The following is a description of a gene set: Human Gene Set: GOBP_MYELOID_LEUKOCYTE_CYTOKINE_PRODUCTION species: Homo sapiens Any process that contributes to cytokine production by a myeloid cell., and this is the list of marker genes: RABGEF1, MYD88, RTN4, TGFB2, TLR4, PANX1, P2RX7 (purinergic receptor P2X 7), SPON2 (NCBI Gene Id 10417), NLRX1, TWIST1, NOD1, DDX21, TLR7 (NCBI Gene Id 51284), TGFB3, CD74, TICAM1, EPX, CARD9, LITAF, AXL, BCL6, LAPTM5, BCL10 (NCBI Gene Id 8915), UBE2J1, KIT, RIPK2, LILRB1, PRG2, GPRC5B, PYCARD, TGFB1, ACP5, WNT5A, SYK, SIRT1, FCER1G, MIF, SEMA7A, NR4A3, MAVS, RIGI, MAPKAPK2 (NCBI Gene Id 9261), HLA-G, DDX1, PLCG2, CAMK4, TLR3, CD36, IRAK3, ATG9A, DHX36, CUEDC2